Given this list of marker genes Pagr1a, Tnfsf4, Msh2, Peli1, Hmces, Paxip1, Parp1, Kmt5b, Shld3, Ercc6, Kat5, Shld2, Skp2, Rif1, Zcwpw1, Il4, Mrgbp, Yeats4, Helq, Rad51ap1, Ube2b, Pms2, Wdr48, Actl6a, Mad2l2, Ercc2, Il2, Exosc3, Actb, Hdgfl2, Meaf6, Ruvbl1, Arid2, Crebbp, Ptprc, Nsd2, Brd8, Mlh1 (mutL homolog 1), Epc2, Tbx21, Tfrc, Pias4, Trp53bp1, Ifng, Trrap, Dmap1, Epc1, Timeless, Blm, Atad5, Clcf1, Tgfb1, Rnf126, Mrnip, Cd40, Prdm9, Ooep, Rnf8, Prmt1, Fancb, Morf4l1, Ruvbl2, Was, Tnfsf13, Shld1, Mbtd1, Morf4l2, Ep400, Khdc3, Vps72, Wrap53, Ing3, Stat6, Actr2, Fus, Cd28, Exosc6, Kmt5c, here is a description of the gene set: Any process that activates or increases the frequency, rate or extent of DNA recombination. species: Mus musculus Mouse Gene Set: GOBP_POSITIVE_REGULATION_OF_DNA_RECOMBINATION